The following is a description of a gene set: studied in species Homo sapiens Human Gene Set: REACTOME_NTRK2_ACTIVATES_RAC1 NTRK2 activates RAC1, and this is the list of marker genes: BDNF, DOCK3, NTRK2, FYN, RAC1